The following is a description of a gene set: species: Homo sapiens Reactome Pathway: Dopamine Neurotransmitter Release Cycle part of: Neurotransmitter release cycle Dopamine neurotransmitter cycle occurs in dopaminergic neurons. Dopamine is synthesized and loaded into the clathrin sculpted monoamine transport vesicles. The vesicles are docked, primed and fused with the plasmamembrane in the synapse to release dopamine into the synaptic cleft., and this is the list of marker genes: TSPOAP1, UNC13B, VAMP2, STXBP1, SYN2, SLC18A2, RIMS1, SYN3, APBA1, SNAP25, LIN7B, PPFIA1, PPFIA2, SYT1, PPFIA3, SYN1, RAB3A, CASK (NCBI Gene Id 8573), CPLX1, LIN7C, STX1A, LIN7A, PPFIA4